Given this list of marker genes COCH (cochlin), LYSET, TWF1 (twinfilin actin binding protein 1), DNAJC6, ARFGEF2, IGF2BP3, DBF4, SLC50A1, TFRC, FEN1, NEK2, DLGAP5, SLBP (NCBI Gene Id 7884), MEMO1, SFN, ARPC1A, H2AZ1, SUZ12, NARF, TUBG1, MCM6, UBE2S (NCBI Gene Id 27338), NDUFA4L2, CENPA, USP1, BUB1B, MCM2, SLC38A1, ECT2, DDOST, CENPU, MKI67, BLTP2, ABCG1, SLC39A6, HLTF, RRM1, UPF3B, PKM, OIP5, SMC2, MCM3, TFPI, NPC1, RRAGD, XK, PTH2R, SLC26A2, MAPK1, TYMS, KIF4A, CCNE2, IARS1, here is a description of the gene set: Hepatocellular carcinomas (HCCs) are a heterogeneous group of tumors that differ in risk factors and genetic alterations. We further investigated transcriptome-genotype-phenotype correlations in HCC. Global transcriptome analyses were performed on 57 HCCs and 3 hepatocellular adenomas and validated by quantitative RT-PCR using 63 additional HCCs. We determined loss of heterozygosity, gene mutations, promoter methylation of CDH1 and CDKN2A, and HBV DNA copy number for each tumor. Unsupervised transcriptome analysis identified 6 robust subgroups of HCC (G1-G6) associated with clinical and genetic characteristics. G1 tumors were associated with low copy number of HBV and overexpression of genes expressed in fetal liver and controlled by parental imprinting. G2 included HCCs infected with a high copy number of HBV and mutations in PIK3CA and TP53. In these first groups, we detected specific activation of the AKT pathway. G3 tumors were typified by mutation of TP53 and overexpression of genes controlling the cell cycle. G4 was a heterogeneous subgroup of tumors including TCF1-mutated hepatocellular adenomas and carcinomas. G5 and G6 were strongly related to beta-catenin mutations that lead to Wnt pathway activation; in particular, G6 tumors were characterized by satellite nodules, higher activation of the Wnt pathway, and E-cadherin underexpression. CONCLUSION: These results have furthered our understanding of the genetic diversity of human HCC and have provided specific identifiers for classifying tumors. In addition, our classification has potential therapeutic implications because 50% of the tumors were related to WNT or AKT pathway activation, which potentially could be targeted by specific inhibiting therapies. Up-regulated genes in hepatocellular carcinoma (HCC) subclass G23, defined by unsupervised clustering. from publication Boyault S, Rickman DS, de Reyniès A, Balabaud C, Rebouissou S, Jeannot E, Hérault A, Saric J, Belghiti J, Franco D, Bioulac-Sage P, Laurent-Puig P, Zucman-Rossi J (PMID 17187432) Human Gene Set: BOYAULT_LIVER_CANCER_SUBCLASS_G23_UP studied in species Homo sapiens